Given this list of marker genes PAX8, PAX2, STAT1, CTNNB1, GDNF, LIF, WNT9B, here is a description of the gene set: studied in species Homo sapiens Human Gene Set: GOBP_REGULATION_OF_MESENCHYMAL_TO_EPITHELIAL_TRANSITION_INVOLVED_IN_METANEPHROS_MORPHOGENESIS Any process that modulates the rate, frequency or extent of the transition where a mesenchymal cell establishes apical/basolateral polarity,forms intercellular adhesive junctions, synthesizes basement membrane components and becomes an epithelial cell that will contribute to the shaping of the metanephros.